The following is a description of a gene set: Cytokines mediate cell-cell communication in the immune system and represent important therapeutic targets. A myriad of studies have highlighted their central role in immune function, yet we lack a global view of the cellular responses of each immune cell type to each cytokine. To address this gap, the authors created the Immune Dictionary, a compendium of single-cell transcriptomic profiles of more than 17 immune cell types in response to each of 86 cytokines (>1,400 cytokine-cell type combinations) in mouse lymph nodes in vivo. A cytokine-centric view of the dictionary revealed that most cytokines induce highly cell-type-specific responses. For example, the inflammatory cytokine interleukin-1β induces distinct gene programmes in almost every cell type. A cell-type-centric view of the dictionary identified more than 66 cytokine-driven cellular polarization states across immune cell types, including previously uncharacterized states such as an interleukin-18-induced polyfunctional natural killer cell state. Genes negatively differentially expressed in cell type: CD4+ T cell upon treatment with cytokine: IL-17A in mouse lymph nodes in vivo. from publication Cui A, Huang T, Li S, Ma A, Pérez JL, Sander C, Keskin DB, Wu CJ, Fraenkel E, Hacohen N (PMID 38057668) Mouse Gene Set: CUI_T_CELL_CD4_IL17A_RESPONSE_DN species: Mus musculus, and this is the list of marker genes: Hspa1a, Hspa1b, Jun, Fos, Junb, Tsc22d3